Given this list of marker genes LILRB2, NR5A2, CD3E, LILRB4, TGFBR2, ITCH, CBLB, HLA-G, FOXP3, IDO1 (indoleamine 2,3-dioxygenase 1), here is a description of the gene set: Any process that activates or increases the frequency, rate, or extent of T cell tolerance induction. species: Homo sapiens Human Gene Set: GOBP_POSITIVE_REGULATION_OF_T_CELL_TOLERANCE_INDUCTION